Given this list of marker genes RAB14, RAB30, RAB27B, RAB9B, RAB22A, RAB6B, RAB29, RAB33B, RAB39A, RAB3C, RABGGTA, RAB34, PTP4A2, RAB23, RAB5A, RAB2A, RAB10, RAB18, RAB7A, RAB40C, RAB12, RAB5C, RAB20, RAB11B (NCBI Gene Id 9230), RAB9A, RAB36, RAB26, RAB19, RAB3A, RAB27A, RAB32, RAB41, RAB8A, RAB1B, RAB3B, RAB17, RAB43, RAB8B, RAB13, RAB37, RAB6A, RAB21, RAB24, RAB39B, RAB31, RABGGTB, RAB40A, RAB44, RAB15, RAB4B, RAB33A, RAB1A, RAB35, RAB4A, RAB7B (RAB7B, member RAS oncogene family), RAB25, RAB11A, RAB2B, CHM, RAB3D, RAB42, RAB40B, RAB38, RAB5B, CHML, here is a description of the gene set: Human Gene Set: REACTOME_RAB_GERANYLGERANYLATION RAB geranylgeranylation studied in species Homo sapiens